The following is a description of a gene set: species: Homo sapiens Xeroderma pigmentosum (XP) and trichothiodystrophy (TTD) syndromes are characterized by deficiency in nucleotide excision repair pathway, but with distinguished clinical manifestations. While XP patients exhibit a high frequency of skin cancer, TTD patients are not cancer prone. The relation between lack of DNA repair and their clinical manifestations was investigated through analysis of the transcriptional profile of 12,600 transcripts in two isogenic cell lines with different capabilities of DNA repair. These cell lines result from a stable transfection of the XPB-TTD allele into XP complementation group B fibroblasts, from an XP patient who also have clinical abnormalities corresponding to Cockayne's syndrome (CS). The microarray assays performed under normal growth conditions showed the expression of distinct groups of genes in each cell line. The UVC-transcription modulation of these cells revealed the changes in 869 transcripts. Some of these transcripts had similar modulation pattern in both cells, although with eventually different time patterns for induction or repression. However, some different 'UVC signature' for each cell line was also found, that is, transcripts that were specifically UV regulated depending on the DNA repair status of the cell. These results provide a detailed portrait of expression profiles that may potentially unravel the causes of the different phenotypes of XP/CS and TTD patients. Human Gene Set: DACOSTA_UV_RESPONSE_VIA_ERCC3_COMMON_DN Common down-regulated transcripts in fibroblasts expressing either XP/CS or TDD mutant forms of ERCC3, after UVC irradiation. from publication da Costa RM, Riou L, Paquola A, Menck CF, Sarasin A (PMID 15608684), and this is the list of marker genes: CUL1, GSK3B, FUBP1, PDE8A (NCBI Gene Id 5151), NFYC, AGAP1, USP24, HOMER1, PPP2R5C, IRS1, XPO1, GTF2F2, CRY1, WAPL, PALM2AKAP2, MARK3, SLC4A7, ARHGAP12, ATRX, JARID2, ACSL3, FERMT2, MAN2A1, ADGRG6, CAMSAP2, SPOP, PAIP1, DLC1, RBM39, PUM1, PAFAH1B1, KAT6A (NCBI Gene Id 7994), ZNF148, RBFOX2, USP6, SCAF8, GMPS, CEMIP, NMT2, CREB1, ZFYVE9, DUSP1, OGT, STK39, CDC42BPA, ADSL, TAF4, KIF2A, LHFPL2, BLM, SLC25A13, PBX3, DYRK1A, MICAL3, EXT1, TCF7L2, RABGAP1, MAP4K5, HIVEP1, BLTP1, OSBPL8, SERPINE1, CKAP5, YAP1, KLF6, CLASP1, INPP5F, FXR1, PTK2, IL1RAP, CDK13, SRSF7, PMS1 (NCBI Gene Id 5378), EIF4G3, TRIM37, KIF11, TRAM2, JUN, TGFB2, SNX13, SMC5, UVRAG, DST, PIP4K2A, STRN3, NRG1, FARS2, PPFIA1, FYN, PTPRA, TLE4, MGAT5, THBS2, KIF5C (kinesin family member 5C), EPHA4, CCDC93, PRKCA, NR3C1, LARS2, PCMT1, GOLGA4, MAPK6, BHLHE40, HEG1, NUP153, PTPRK, PARD3, TRIP12, PPP2CA (protein phosphatase 2 catalytic subunit alpha), NDC80, ARID5B, AFF1, GAPVD1, SMAD3, USP13, RYK, NCOA3, CTBP2, NPIPB5, CHD1, BCAR3, NUMB, CDYL, STK24 (serine/threonine kinase 24), SPECC1L, ASCC3, MTREX, CUX1, DAPK1, ARHGEF7, ATXN2, SAMD4A, ZDHHC17, FUT8, UGCG, FRYL, ITSN1, EGFR, TLK2, MARCHF7, TBL1X, ASAP2, PRRC2C, KLF10 (NCBI Gene Id 7071), KIF20B, ROCK2, HIRA, NRIP1 (NCBI Gene Id 8204), PARN, TASOR, PAWR, FBXL7, CHSY1, FAM169A, CREBBP, MGLL, DOP1B, MARCHF6 (NCBI Gene Id 10299), RAB3GAP1, LRPPRC, CXCL12 (NCBI Gene Id 6387), UBE2G1, HELZ, ARFGEF1, TMEM131, UBL3, STAU2, KAT6B, CLIP1, PIKFYVE, BAZ2B, RCOR1, DNMBP, ZMYND11, IL7R, ZMYM2, FTO, SRSF3, NVL, PHIP, MAP1B, PHLPP1, MEIS2, IGF2BP3, E2F3, TRAK1, CRIM1, MYBL1, PHF21A, CBLB (Cbl proto-oncogene B), ZNF804A, CERS6, SEC24A, CREB3L2, CASP8, PTENP1, SMCHD1, ZHX2, ZNF292, SEMA3C, KRIT1, PALS2 (NCBI Gene Id 55569), TLK1 (tousled like kinase 1), SUZ12, RGS20, PPP2R3A, APPBP2, NEK7, NFIB, BAZ1A, PPP3CB, CD2AP, SMURF2, SLK, STAM, ZZZ3, NCK1, HNRNPDL, CDC27, CDS2, C2CD3, MYCBP2, PMM2, RBPJ, TAB2, MTF2, FNBP1L, TDRD7, FGF2, PRMT3, SWAP70, CEP135, PARG, FILIP1L, PPP2R5E, TRIO, CNOT4, U2SURP, RB1, GINS1 (NCBI Gene Id 9837), MAMLD1 (NCBI Gene Id 653998), CLEC16A, NAA20, XRCC4, ID1 (NCBI Gene Id 96820), SRPK2, MDN1, CENPE, RNF13, BDNF, LARP4, CNOT2, RFTN1, ACVR1, UBE3A, LYN, PKD2, ANKMY2, RRAS2, G6PD, STIL, FGF5, EHBP1, SRGAP2, IBTK, COL5A2, UTP18, ZMIZ1 (NCBI Gene Id 57178), MSH2, FNDC3A, CEP350, RAPGEF2, SEC14L1, WDR7, MED13L, DNAJC13, F3, MELK, PRKCI, USP32P2, QKI, CASK, CHD9, KPNA3, GIGYF2, NR2F2, BUB1B, AUH, MECP2, MYC, CEP170, E2F2, HIVEP2, TUBGCP3, GNAQ, DHX15, MYO1B, ARHGAP29, WNT5A, RBMS1P1, SHB, CCSER2, LIMCH1, ZNF638, KIF14, PIK3C3, ORC5, IPO7, UPF2, PPP1R12A, FAM171A1, FOXN3, PTPN2, EIF4E, CDK8, ADAM10, AFAP1, EPS8, MNAT1, ADARB1, LARP4B (La ribonucleoprotein 4B), ATP2B1, WASF3, SETD2, FOXK2, CCN2, PPM1B, CLASP2, FOXD1, GLRB, CCN1, MBD2, NBN, ZMYM4, ABI1, USP9X, SCHIP1, NPEPPS, SOCS5, ORC2, TUT4, TIPARP, NEDD4, NCOA1, CENPA, ATAD2B, STAG1, SLC7A1, R3HDM2, MTCL1, ATP13A3, ATP11B, ANKS1A, STARD13, FOXO3, PHLPP2, UBR2, UBR5, MKLN1, MBNL1, MED13, MAP2K1, WASHC4, PNISR, RNGTT, FCHSD2, MARF1, WDR43, TIAM1, STK3, PRKACB, C2CD2, PIBF1, HMGXB4, ANKRD17, CDK17, TCF12, SEMA5A, RBM6, PKN2, TOPBP1, PRR3, CRADD, EVI5, TRIM2, MID1, CENPF, MTX2, GBE1, RUNX1, OPA1, ZHX3, BBX, SATB2, PTPN12, RBMS1, R3HDM1, KIF23, ZC3H4, RGS7, PDS5A, NUAK1 (NUAK family kinase 1), SMARCA2, SEPTIN9, TOP2A, SSBP1, PICALM, TP53BP2, REV3L, PPP2R2A, ARIH1, TSPAN5, SEC24B, USP12, MYO10, RPGR (NCBI Gene Id 6110), RAB6A, VPS13A, TRIM33, EPS15, FAT1, C2CD5, KDM5A, MOK, ZMYND8, PEX3, VEGFC, BARD1, UBE2D2, ENC1, TLE1, RAD23B, ATF2, FOXJ3, WRN, TRAPPC8, RASA1, KLF7, PHF3, NREP, SPEN, AKAP9, DCUN1D4, PUM2, CLOCK, SOS1, DENND5A, NUP98, BPTF, PRIM2, BRCA1, ATR, WWC1, FBXW11 (F-box and WD repeat domain containing 11), MAP2K4, FLNB, TJP2 (NCBI Gene Id 9414), OXSR1, ITSN2, CAP2, TRRAP, PKP4, UCK2, DPYD, PJA2, PUM3 (pumilio RNA binding family member 3)